Given this list of marker genes Wrn, Rfc2, Recql5, Chd4, Mcm5, Rfc5, Dhx9, Chtf18, Rad51, Rtel1, Dna2, Mcm8, Mcm3, Blm, Ascc3, Ercc6l, Chd7, Pif1, Twnk, Rad54l2, Polq, Mcm7, Helb, Ercc3, Rad54l, Smarcad1, Chtf8, Dscc1, Ighmbp2, Hfm1, Gtf2f2, G3bp1, Atrx, Ruvbl1, Chd1, Mcm9, Dqx1, Wrnip1, Rfc3, Chd5 (chromodomain helicase DNA binding protein 5), Mcm2, Helq, Chd6, Ddx11, Chd9, Mcm4, Chd2, Ercc2, Mcm6, Recql, Ruvbl2, Chd1l, Fbh1, Rfc4, Chd8, Recql4, here is a description of the gene set: studied in species Mus musculus Mouse Gene Set: GOMF_SINGLE_STRANDED_DNA_HELICASE_ACTIVITY Catalysis of the reaction: ATP + H2O = ADP + phosphate, in the presence of single-stranded DNA; drives the unwinding of a DNA helix.